Given this list of marker genes PHIP, MID1, EDN1, CAPN15, FBXW7, GLI3 (GLI family zinc finger 3), SPTBN1, here is a description of the gene set: Laryngeal cleft Human Gene Set: HP_LARYNGEAL_CLEFT studied in species Homo sapiens Presence of a gap in the posterior laryngotracheal wall with a continuity between the larynx and the esophagus.